Given this list of marker genes FKRP, ADAMTS18, MUC5AC, C1GALT1C1, B3GNT8, GALNT4, GALNTL6, ST6GALNAC3, MUC16, B3GNT2, SPON1, GCNT4, GALNT12, ST3GAL3, ADAMTS17 (ADAM metallopeptidase with thrombospondin type 1 motif 17), ADAMTS12, GALNT1, THSD4, THSD1, ST6GAL1, MUCL1, RXYLT1, ADAMTS3, SSPOP, GALNT10, ADAMTS8, POFUT2, SPON2, ADAMTS9, POMT2, MUC17, MUC1, B3GNT4, FKTN (fukutin), ADAMTSL4, MUC19, MUC7, GALNT3, GALNT16, MUC15, MUC12, POMGNT1, GCNT3, C1GALT1, SLC35A4, THSD7A, B3GLCT, ADAMTS6, SEMA5B, ST6GALNAC2, MUC13, B4GALT6, ADAMTS20, GALNT6, B3GNT7 (NCBI Gene Id 93010), ST6GALNAC4, POFUT3, ADAMTS2, GALNTL5, THBS2, ADAMTSL2, LARGE1, GCNT7, MUC2, MGAT5B, POMGNT2, GALNT7, B3GNT9, GALNT9, ST3GAL1, MUC3A, GALNT11, MUC20, MUC21, LARGE2, ADAMTS7, ST3GAL4, THSD7B, GALNT15, MUC3B, GALNT13, ADAMTS16, CFP, CHST4, QTGAL, A4GNT, CHST10, ADAMTSL3, B3GNT5, GALNT17, B3GALNT2, GALNT5, MUC4 (NCBI Gene Id 55804), MUC6 (NCBI Gene Id 4588), MUC5B, ADAMTS14, SLC35A1, THBS1, ADAMTSL5, B3GNT6, POFUT4, DAG1, CRPPA, SEMA5A, EMID1, ADAMTS5, POMT1 (NCBI Gene Id 10585), ADAMTS4, MMRN2, ADAMTSL1, ADAMTS15, GALNT2, ADAMTS19, B3GNT3, ST3GAL2, POMK (NCBI Gene Id 84197), ADAMTS13, MMRN1, ADAMTS1, GCNT1, B4GAT1 (beta-1,4-glucuronyltransferase 1), GALNT8, B4GALT5, ADAMTS10, SBSPON, GALNT14, GALNT18 (NCBI Gene Id 374378), here is a description of the gene set: species: Homo sapiens O-glycosylation is an important post-translational modification (PTM) required for correct functioning of many proteins (Van den Steen et al. 1998, Moremen et al. 2012). Reactome Pathway: O-linked glycosylation part of: Post-translational protein modification